Given this list of marker genes CNNM4, NBAS, PDE6H, ATF6, PDE6C, CNGB3, GNAT2, OPN1MW, OPN1LW, CNGA3, RPGR, here is a description of the gene set: Human Gene Set: HP_MONOCHROMACY studied in species Homo sapiens Monochromacy Complete color blindness, a complete inability to distinguish colors. Affected persons cannot perceive colors, but only shades of gray.